The following is a description of a gene set: from publication Pello OM, De Pizzol M, Mirolo M, Soucek L, Zammataro L, Amabile A, Doni A, Nebuloni M, Swigart LB, Evan GI, Mantovani A, Locati M (PMID 22067385) In response to microenvironmental signals macrophages undergo different activation, indicated as classic/M1 and alternative/M2 polarization. C-Myc transcription factor could be an essential player in M2 polarization. Functional relevance of c-Myc in M2 macrophage biology is investigated by evaluating the effect of 100-58F4, on the transcriptional profile induced on human macrophages by IL-4. Human Gene Set: GSE32164_ALTERNATIVELY_ACT_M2_VS_CMYC_INHIBITED_MACROPHAGE_DN species: Homo sapiens Genes down-regulated in macrophages: alternatively activated M2 versus MYC inhibited., and this is the list of marker genes: ASAH1, HMGCR, BIRC5, CD244, H3-4, OXT, SNHG6, RFC5, CD8A, CBX5, COQ7, TIMM8A, DHRS1, DLAT, ANAPC16, H2AX, SGK1, BRIX1, GALK1, PMM1, RBM3, PLAC8, PELI1, UCK2, PPIA, ACP6, CHEK1, RPS26, METTL5, SERPINI1, SSX2IP, KIN, NKX6-2, CLDND1, CPD, CENPK, ALYREF, PCBP1, CD7, CCDC28B, SLC25A4, RGS10 (NCBI Gene Id 6001), NSG1, GMFB, RASGRP2, TCAP, PSAT1, GABARAPL1, CA2, POLR2D, NCAPH, DBI, NDFIP2, POLA1, H1-10, MRPL27, RALA, CAPN3, ANXA2, S100A1, MAPKBP1, DAD1, DHCR24, COL1A2, CD9, ROM1, SASS6, GART, CYTH3, PRMT1, BUB1, CKAP2, ID3, CKS2 (NCBI Gene Id 1164), NEK2, OSTF1, KLF7, MYL11, ERH, KYAT3, CDCA8, IL5, FNDC1, AP3S2, RASD1, CDH6, AQP2, ELOVL6, CDC6, KIT, TSC22D1, ACTN1 (actinin alpha 1), PHF5A, SMC4, MRTO4, MRPS28, DHFR, TCF7, CDCA5 (NCBI Gene Id 256676), CHRNG, DRC1, PLP2, SELL, DTL, ACSL4, PCLAF, NFIC, RSU1, GCSH, ABHD14A, MLLT11, TXN, KIF23, SOX4, MEMO1, ITGA4, MAP4K4, EZH2, ZAN, SLC30A4, SERF1A, MEIG1, ANLN, ANAPC13, AMZ2, GCOM1, TACC3, SQLE, SUV39H2, PDLIM1, PRC1, TKT, DDX21, CYP51A1, CDK1, EMB, EMP3, IDI1, ALCAM (NCBI Gene Id 214), CKS1B, DHRS4, LMNB1, TYK2, CDC20, RFC3, RASA3, UTF1, ARL6, BAX, YBX3, TRIP13, EIF4G3, MAD2L1BP, LAG3, PRIM1, ASF1B, TRIM59 (NCBI Gene Id 353185), GAB2, CLCN3, S1PR1, KDELR2, PLSCR1, MBTD1, CNN3, LIG1, SNRPC, APEX1, ITGAE, IFT25, POLE2, TOP2A, IDH2, TFPI, CRIP1, DNAJC9, POLD2, FXYD7, MCOLN2, ATP5IF1, RHOH (NCBI Gene Id 399), CACNA1B, MTM1, AURKA, SLC7A5, ASPM, HMGB3, BAG2, YIPF4 (NCBI Gene Id 84272), KIF11, NSG2, SNAP23 (NCBI Gene Id 8773), RBM17, FHL2, USP3, ATF5, RACGAP1, NUSAP1, IMPA2, PFN1, SLC31A1